Given this list of marker genes Lss, Fli1, Ephb2, Ifi204, Enpep, Slit2, Ccl12, Insig1, Rbp1, AW551984, Ebf3, Stard4, Pik3ap1, Igfbp6, Rpl39l, Epha3, Pdgfra, Meox1, Ccn3, Mfap4, Ahr, here is a description of the gene set: from publication Plasari G, Calabrese A, Dusserre Y, Gronostajski RM, McNair A, Michalik L, Mermod N (PMID 19752192) Mouse Gene Set: PLASARI_NFIC_TARGETS_BASAL_DN studied in species Mus musculus Transforming growth factor beta (TGF-beta) and platelet-derived growth factor A (PDGFAlpha) play a central role in tissue morphogenesis and repair, but their interplay remain poorly understood. The nuclear factor I C (NFI-C) transcription factor has been implicated in TGF-beta signaling, extracellular matrix deposition, and skin appendage pathologies, but a potential role in skin morphogenesis or healing had not been assessed. To evaluate this possibility, we performed a global gene expression analysis in NFI-C(-/-) and wild-type embryonic primary murine fibroblasts. This indicated that NFI-C acts mostly to repress gene expression in response to TGF-beta1. Misregulated genes were prominently overrepresented by regulators of connective tissue inflammation and repair. In vivo skin healing revealed a faster inflammatory stage and wound closure in NFI-C(-/-) mice. Expression of PDGFA and PDGF-receptor alpha were increased in wounds of NFI-C(-/-) mice, explaining the early recruitment of macrophages and fibroblasts. Differentiation of fibroblasts to contractile myofibroblasts was also elevated, providing a rationale for faster wound closure. Taken together with the role of TGF-beta in myofibroblast differentiation, our results imply a central role of NFI-C in the interplay of the two signaling pathways and in regulation of the progression of tissue regeneration. Genes down-regulated in MEF cells (embryonic fibroblast) upon knockout of NFIC.